The following is a description of a gene set: species: Homo sapiens Abnormal circulating branched chain amino acid concentration Any deviation from the normal concentration of a branched chain family amino acid in the blood circulation. Human Gene Set: HP_ABNORMAL_CIRCULATING_BRANCHED_CHAIN_AMINO_ACID_CONCENTRATION, and this is the list of marker genes: BCKDK, ATP5F1B, BCKDHA, BCKDHB, MCCC2, MCCC1, PPM1K, MICU1, BCAT2, DLD